Given this list of marker genes PAPSS2, PAPSS1, GSR, TXNRD1, here is a description of the gene set: Reactome Pathway: Metabolism of ingested H2SeO4 and H2SeO3 into H2Se part of: Selenoamino acid metabolism Ingested selenic acid (H2SeO4) and selenite (SeO3(2-)) are reduced to hydrogen selenide (H2Se) through a combination of actions involving bifunctional 3'-phosphoadenosine 5'-phosphosulfate synthase 1 and 2 (PAPSS1/2), PAPSe reductase (PAPSeR), and thioredoxin reductase 1 (TXNRD1). studied in species Homo sapiens